Given this list of marker genes PPA2, CA1, RNASE1, PLA2G3, PLA2G7, CES1, MAP1S, EYA2, ANXA8, TOE1, INPP1, CDCA2, NTHL1, OC90, TMBIM6 (transmembrane BAX inhibitor motif containing 6), DESI2, ABHD16B, ANXA3, SSU72L2, PPP3R1, GTF2F1, MYH8, SNCB, INPPL1, LPIN3, MRPL44, PPP3R2, PTPRH, DUSP7, XRCC3, PTEN, PPP1R11, SBF2, APOA2, ALPP, RNASE12, EPHX2, PPP1R15B, APTX, PPP2R5E, PTPN23, LCK, MBD4, PPEF2, PLPP5, PDE4B, PPP1R1A, APOC1 (NCBI Gene Id 341), PLCL1, G6PC1, ARSD, URI1, LHPP, ACOT11 (NCBI Gene Id 91515), PAFAH1B2, ABHD12B, SLFN12, LAS1L, AGO3, TNS1, ANGPTL3, NYNRIN, ENSA, PDE6B, PRDX6, EXD2, DFFA, LYPLAL1, SMPDL3A, N4BP1, EYA3, INPP4B, PTPN20, IGFBP3, EXO5, HAGH, LIPM, PPP1R16A, PLCH2, ELAC2, PNPLA2, MTMR6, NOTUM, ESD, PPP1R3B, DCLRE1B, DNASE1L3, DNASE1L2, PTPRT (protein tyrosine phosphatase receptor type T), MRE11 (NCBI Gene Id 4361), PLEK, RPAP2, EXOSC6, PGP, RPPH1, ABHD11, PNLIPRP1, EME1, OGG1, PLCB2, PLAAT4, ABHD12, CTDSP1, INPP5D, DTD1, IMPA1, STS, C11orf54, PABIR2, PTPRQ, TIGAR, PTP4A1, BPNT1, RNASET2, PPP5C (protein phosphatase 5 catalytic subunit), CNOT2, ALPL, SEC23IP, RNASE6, ARPP19, EPM2A, ANXA2P2, PFKFB3, PPM1N, ACOT6, SMG6, APMAP, STYXL2, HAGHL, ANGPTL4, ABCE1, PTPRZ1, CASP3, LIPF (NCBI Gene Id 8513), FRA10AC1 (NCBI Gene Id 57208), DBR1, VCAN, NT5C3A, NT5DC1, CTNND1, EXOSC8, PTPN1, ARHGAP6, PLA2G4D, SLC39A10, PGLS, RPP21, PGAP6, INTS11, ERI2, PPP1R36, PFKFB1, DESI1, EXOSC3, G3BP1, CA3, PLPP7, MYH3, H6PD, DNASE2B, SLX1A, GDE1, SSH1, SH3RF2, INPP4A, AGO4, PNPT1, PTPN21, LYPLA2, PTPN18, ABHD13, XRN2, PNPLA4, RNASE4, RBBP8, PDE8B, VRK3, PP2D1, PDGFRA, PLCZ1, INPP5J, ARSA, PDE1C, PPP1R14A, GDPD4, PLCD1, RNH1, ENPP1, PTPN11, LIPC, PTN, TPRN, APOH, ABHD10, LCAT, NOB1, DIS3L, PPP1R10, NT5DC3, POP1, ACHE, PRUNE1 (prune exopolyphosphatase 1), HSP90AB1, DMPK, SLX1B, BPHL, PLA2G2A, TIPRL, SACM1L, PNLIP, TREX1, FASN, PDE8A, PARN, FAN1, F2RL2, ISG20, MINPP1, ANKZF1, PNPLA5 (NCBI Gene Id 150379), EYA1, ANXA4, XRCC1, PTPN4, PPP6C, ENDOU, PHACTR3, CWF19L1, ABHD5, RNASE13, ARMT1, REXO2, RCAN3, TSEN34, ARSH, PLPPR2, SSH2, PTPN12, SIAE, PDP2, ENPP6, PLA2G4C, PLCG1, PPP3CC, PLCXD3, DUSP6, G6PC3, PPM1F, CES4A, PPM1A, THEM5, DUSP10, ERCC5, CCL3, ACOT1, PHLPP2, INPP5F, DUSP8, PTRH2, APLF, ACOT2, ANKLE2, MTMR14, PPP2R2B, ABHD3, INPP5E, PIKFYVE, RPP38, PAN3, CRY2, ENDOV (endonuclease V), PPP1R1C, LDAH, RNASEK, ATP1A1, PDPK1, DUSP14, ACAA2, PTPRD, PPP4R3C, PIWIL3, DNASE1, PPP6R1, CNEP1R1, IGBP1, NT5DC4, ENPP7, BMP2K, PLPP6, ABHD8, GDPD5, SLFN13, PLAAT3, HDDC2, CNOT1, EXOSC4, MTMR10, STX4 (syntaxin 4), PPP6R2, MYG1, SULF2, CCR1, APOA5, YBEY, PPM1K, PFKFB4, MPPE1, ARSK, PGAM5, PPP3CA, SSU72L4, PDE7B, OLAH, PLA1A, PNKP, SSU72L3, ZC3H12B, APOC3, PPP2CB, PDE2A, PPP1CA, PPP4R1, ARSI, GPIHBP1 (NCBI Gene Id 338328), PLPP2, DUSP9, PLCXD1, PDC, THEM4, PABIR3, DUSP21, MDP1, DUSP2, PAFAH2, SULF1, POLE, SSU72, PLCB4, CES3, EXOSC7, AADACL3, LIPJ, RNASE8 (ribonuclease A family member 8), NDST1, LPL, PPP1R2B, PLA2G2F, ABCD2, PLCD3 (phospholipase C delta 3), ARSF, PTPRO, PFKFB2, PPP4R3A, NT5C3B, IGFBP2, MTMR8, ACSBG2, PLAAT1, ENDOG, PTP4A2, MGLL (monoglyceride lipase), PDE1A, PPP2R2A, BTK, GALNS, ISG20L2, PON3, EXO1, IDS, LIPG, PTPRK, PPM1H, MTMR3, NOCT, MTM1, EXOSC9, CTDP1, LACTB2, ANXA2, DDHD1, PPP3CB, TNS3, ACOT9, PIWIL1, PTPRE, DDHD2, NAPEPLD, PLA2G15, PHOSPHO2, PHLPP1, RNASEH2A, PPP1CB, AADAC, SGPP1, ANKLE1, PLD2 (phospholipase D2), MRPL58, DCPS, MEIOB, CLN5, NME8, CPSF3, PON1, SYNJ2, PTPRU, SSU72L6, PNPLA7, PPP1R35, PTPA, TSN, CNP, REXO1, DIS3L2, PDP1, PPP1R14B, PPP1R37, POP5, LPIN2, PTER, CCL8, PLB1, NDST2, CNOT6L, STYXL1, PLCB1, PPEF1, PON2 (NCBI Gene Id 5445), CLC, FYN, POLRMT, MTMR7, PPP1R12C, CD33, PLCL2, DCLRE1A, ANG, PAN2, RNASE2, PDE5A, USB1, PLPPR3, PPP2R1B, NCEH1, TESC, PPM1M, PPM1J, PLAAT5, PTPN5, PXDNL, SGSH, PPM1E, PPT2, PNLDC1, CEL, PPP4R2, EXOSC10, STYX, TPTE2, LIPI, RAD51C, MTMR4, ARSL, TATDN3, CPT1C, DCP2, DUSP15, PPP1R26, C1QBP, PPP1R12A, ATP1A2, TNFAIP6, HADHA, EXD1, PPP4C, PPP1R3C, PTPN6, TNS2, GNA12, PTPN13, CPPED1, ENSG00000293349, PIP4P2, SBF1, HACD2, PPP1R16B, ZC3H12A, SCGB1A1, GDPD3, ERN1, POP4, CALM1, AADACL2, HELZ2, LIPA, RNASEH1, PDE7A, PSPH, DYNLL1, NT5C1A, MTMR11, POLG (NCBI Gene Id 5428), PLA2R1, ILKAP, INPP5K, PLBD2, CDC14A, PHACTR1, PLPP4, SND1, APEX1, PPM1B, ARSJ, EIF2AK2, CILP2, PPP1R27, PANK4 (NCBI Gene Id 55229), PDGFRB, ELFN2, CDC25A, FBP2, RAD1, DAGLB, MTMR12, UBASH3B, PTPRJ, THNSL2, PPP2R5C, MACROD2, ALPG (NCBI Gene Id 251), EXD3, ANXA5, PTPRC, PLPPR4, AOAH, CNOT7, CES2, EXOSC2, SET, RPP25, OCRL, PDE4A, ITGA1, GDPD2, RNGTT, PITPNM3, REXO1L1P, ABHD17B (abhydrolase domain containing 17B, depalmitoylase), LMTK2 (lemur tyrosine kinase 2), CTDNEP1, ZC3H12D (NCBI Gene Id 387078), RNASE7, SAG, RNASE11, ACY3, DUSP26, ELAC1, GPCPD1, TRIR, SMPD1, PHOSPHO1, N4BP2, PPP2R3B, RNASE10, TAB1, DUSP13B, LIPH, PPP1R2P1, PDE9A, EYA4, RAG1, PTPRS, PLCXD2, SMPD3, PDE12, CAMK2G, PABIR1, BMP2, PNPLA3, BRAT1, BCHE, HSP90B1, PTPN9, PPME1, RNASEL, DAGLA, HTT, FBP1, YWHAB, PPP1R3E, FANCM, SAMHD1, ENOPH1, PLPPR5, AGO1 (argonaute RISC component 1), PNPLA6, MTMR2, PDE6A, PINLYP, PPP1R7, TPTE, PNLIPRP2, TDP2, RPP40, XRN1, CIP2A, PLSCR1, PDE11A, ENDOD1, ASPA, DNA2, SIRPA, MYOZ1, PLCH1, DNASE2 (deoxyribonuclease 2, lysosomal), NME1, PDE10A, PPP2CA, HDDC3, TSEN2, PLCB3, ASPG, EXOSC5, FEN1, DIS3, CILP, SSU72L1, GPLD1, PTPN22, PTRHD1, OARD1, PTPRB (NCBI Gene Id 5787), ACP7, PLA2G12A, HRAS, DTD2, ZRANB3, DLG1, RPS3, SLFN11, NT5E, CCL5, EDNRA, TIMM50, CASR, SLFN14, ACOT7, CTDSP2, DPH7, SHOC2, TSNAX, DXO, GEN1, TEFM, NT5C, CALM2, WRN, ZC3H12C, PNLIPRP3, AGO2, DUSP29, ABHD16A, PLD6, MYH6, DUSP12, ACP3, AZGP1, DNAJC6, PLA2G4A, POLD1, LGALS13, CES5A, ERI1, ABHD2, NANP, ARSG, PLA2G1B, AMBRA1, B3GAT3, PROCA1, PLA2G2E, PPP1R15A, NUDT12, PLCD4, BPNT2, FICD, CHRM1, LYPLA1, RNASE3, NT5DC2, FAM83B, BDKRB2, MBLAC2, RAD50, RGN, ALDH2, DUSP23, PPP1R2C, DUSP13A, TREX2, INPP5A, PTPRA, MUS81, RCAN2, ABHD6, PPP2R2D, ACOT13, RCL1, PPP2R5A, MGME1, BAAT, PPM1D, NME7, MTMR1, ABHD4, PPP4R3B, GM2A (NCBI Gene Id 2760), PPP2R1A, PLPPR1, PLA2G5, RCAN1, PRORP, ANP32E, PPM1G, TATDN1, MBLAC1, INPP5B, PIWIL2, FAAH, PDE3A, CHKA, DUSP4, PIP4P1, SGPP2, RPP14, FAF2, ADPRS, DFFB, ERCC4, PLA2G10, PPP1R12B, BCKDK, SMPD2, ETF1, ZEB2, PLAA, DICER1, FRS2, CCR5, CDKN3, DUSP16, SMPD4, DCLRE1C, PDE3B, PDE6C, MGAT5, PPP2R2C, DUSP19, PLA2G12B, PPP1R14D, PNPLA1 (patatin like phospholipase domain containing 1), PDIA3, HARBI1, PPP1CC, PPM1L, ALPI (NCBI Gene Id 248), DROSHA, PDE1B, ACP4, PLA2G6, ERI3, IMPA2, NME5 (NME/NM23 family member 5), PDE4D, ABHD17A, ANXA1, ABCD3, PTPN3, PHACTR4, PLA2G4E, IAH1, RPP30, ERCC1, PLD3, PLD4, MPPED2, PDE6H, PXYLP1, DUSP1 (dual specificity phosphatase 1), PTPRG, SRC, PDE4C, GNS, DUSP5, PNPLA8, ACOT4, ELFN1, ACP5, POP7, ADPRM (NCBI Gene Id 56985), CTDSPL2, ARL1, PGAP3, PALD1, PDE6G, G6PC2, CDC14C, PPP4R4, PPP1R8, ABHD17C, DUSP3, DUSP11, APEX2 (apurinic/apyrimidinic endodeoxyribonuclease 2), PUDP (pseudouridine 5'-phosphatase), PTPRF, PTRH1, ABHD15, CTDSPL, ACOT8, EME2, PLBD1, CNOT6, NUDT16L1, SMPDL3B, ARF4, PLPP1, DUSP22 (dual specificity phosphatase 22), ENPP3, YWHAE, PAFAH1B3, CNOT8, PLA2G2D, PPP2R5D, CALM3, PLAAT2, UBE3D, PPP1R2, PPP1R9B, PPP1R3D, PDXP, PHACTR2, ERN2, PTPN2 (NCBI Gene Id 5771), PPT1, FIG4, RAD9A, GDPD1, PTPN14, TDP1, LPIN1, PGBD5, DUSP18, NT5M, HIBCH, ENPP2, REXO4, CHRM3, PLA2G2C, NT5C1B, RNASE9, DDX1, PLCG2, PTK2, RIDA, PTPN7, NT5C2, PTPRN, AADACL4, PIWIL4, PNKD, NDST3, BOD1, SYNJ1, CABIN1, PMS2, MARF1, LGALS3, PPP2R3A, PTPRR, PPP1R1B, PPP6R3, DNASE1L1, KHNYN, DUSP28, LIPK, CA2, PGAP1, HDHD2, PPP2R5B, PLA2G4B, PTPDC1, ACP2, CDC25C, SNCA, EXOSC1, TATDN2, CHRM5, EXOG, AEN, REXO5, ACOT12, APOC2, PLD1, PPP1R17, PTPRM, UBLCP1, PLCE1, PPP1R14C (protein phosphatase 1 regulatory inhibitor subunit 14C), PHPT1, PTPMT1, ARSB, LIPE, SSU72L5, RPE65, ABCD1, CDC14B, ACP6, ASTE1, PPTC7, SETMAR, ACP1, LIPN, ABHD1, BIVM, MACROD1, PLPP3, CDC25B, PTP4A3, NUDT16, PTPRN2, SSH3, PLA2G4F, here is a description of the gene set: species: Homo sapiens Human Gene Set: GOMF_HYDROLASE_ACTIVITY_ACTING_ON_ESTER_BONDS Catalysis of the hydrolysis of any ester bond.